The following is a description of a gene set: species: Homo sapiens Genes down-regulated in comparsion of sfActCD4 versus ActCD4 (see Fig. 1 in the paper for details). Human Gene Set: GSE7460_FOXP3_MUT_VS_WT_ACT_TCONV_DN from publication Hill JA, Feuerer M, Tash K, Haxhinasto S, Perez J, Melamed R, Mathis D, Benoist C (PMID 18024188) The transcription factor Foxp3 is usually considered the master regulator for the CD4+CD25+, and this is the list of marker genes: PEAK1, PARD6G, CD2 (NCBI Gene Id 914), MCCC2, PDE5A, ASCC1, NLRP10, SERPINA6, SELL, KCNAB3, MAPK11, CREG1 (NCBI Gene Id 8804), FOXD2, PDGFD, SFSWAP (NCBI Gene Id 6433), SLC30A7, TEF, ESR1, CNPY1, GPR83, SLC14A1, CHST6, VWA8, PHAF1, SPICE1, RAG2, ARL5B, EGLN2, TMC8, FRY, LRRC61, SH3PXD2A, ARHGAP29, AAMDC, GABRR2, DGKZ, APP, AKAP12, IQCF5, KLHL7, ZC3H4, METTL8, MPND, ELOVL7, NIPA1, TMCC3, ATPAF1, LEF1 (NCBI Gene Id 51176), DRC1, TNFSF8, TMEM8B, PPTC7, ID3, ZNF280D, ATP10D (ATPase phospholipid transporting 10D (putative)), ELF2, SNN, IFT46, FGF13, ADPGK, SLC30A4, TANC1, MID1IP1, NSUN4, FOS, AR (NCBI Gene Id 367), BPHL, KLF2, SPEN, KRT72, QPRT, PPM1L, TEX13B, HDAC10, LRRC66, ATP11B, STAMBPL1, ADAMTS6, TPD52L2, TOX, CASC3, ARL4C, CYB5R1, NTPCR, C1QTNF9, PKNOX1, SLC17A9, COL17A1, TRIM35, MCEE, ANKRD50, SLC44A1, IRAG1, TSPAN17, CHAD, PDLIM4, GGACT, RIN2, C1orf198, PIAS1, SMAD4, NREP, TBL1X, TENT4B, KIAA0930, SHE, DUSP7, DNMBP, ATP8A1, ABHD8, C9orf72, SLPI, EPHX1, PANK4, OGDH, XIST, S1PR1, SLC44A2, SYTL1, BTLA, IGFBP4, CCDC88C, LATS2, NAAA, MCOLN3, GCH1, RASL11B, CTNND2, APC (NCBI Gene Id 324), PDS5A, RYR2, ACAA2 (acetyl-CoA acyltransferase 2), MFHAS1, KLF7, MCUR1, ZBTB18, ATP11C, APPL2, WIPF2, ELK4, FILIP1L, CCR7, AMER1 (APC membrane recruitment protein 1), ZNRF3, FNBP1L, BTD, LRATD2, GRAMD4, BRK1, USP7, CYP39A1, ALDH6A1, CD2AP, LTF, MED1, CAMK2D, PLCL2, RFX3, DAPL1, C1orf21, IFT80, SPRY1, USP6NL, PDLIM1, RAB3IP, CAMTA1, RASA1, GNB4, CALCOCO1, USP20, HS3ST3B1, NUDT14, VPS51, USF2 (NCBI Gene Id 7392), AKAP3, NFIX, RAMP1, CDON, RPS6KA2, PDLIM5, IL17RA, TCF7, KANK4, AGAP2, GRK4, CNKSR3, EMP1, PI4KB, SQOR, TCF20 (transcription factor 20), ARIH2, ATP2B1, ASS1, NRP1, MOB3B, CDIP1, PRR16, CEP164